Given this list of marker genes Slc14a1, Aqp9, Aqp7, Slc14a2, Aqp8, Aqp3, here is a description of the gene set: species: Mus musculus Mouse Gene Set: GOMF_UREA_TRANSMEMBRANE_TRANSPORTER_ACTIVITY Enables the transfer of urea from one side of a membrane to the other. Urea is the water soluble compound H2N-CO-NH2.